Given this list of marker genes HBB, CASK, HBA1, HBA2, GPX1, G6PD, here is a description of the gene set: Heinz bodies A type of erythrocyte inclusion composed of denatured hemoglobin. studied in species Homo sapiens Human Gene Set: HP_HEINZ_BODIES